The following is a description of a gene set: Human Gene Set: GOBP_POSITIVE_REGULATION_OF_CYTOSKELETON_ORGANIZATION Any process that activates or increases the frequency, rate or extent of the formation, arrangement of constituent parts, or disassembly of cytoskeletal structures. species: Homo sapiens, and this is the list of marker genes: MAPK15, CD47, NCK1, TRPV4, WNT4, KIRREL1, SEMA5A, ARL2, SDC4, WHAMM, DSTN, SERPINF2, CCDC15 (coiled-coil domain containing 15), PFN3, ARHGEF15 (Rho guanine nucleotide exchange factor 15), RHOC, STMN2, CDC42, BAIAP2, P2RX7, BMP10, ARHGEF10, DCTN1, CARMIL1, BAIAP2L2, MECP2, TPM1, PTK2B (protein tyrosine kinase 2 beta), PRKCE, NUP62, MTOR, AMOT, MTSS1, PPM1E, CTTN, DYNC1H1, SPAST (spastin), SKA1, PFN1, SMAD3, MET, EDN1, HCK, NUMA1, HSPA1B, RHOA, MYOC, SLAIN1, DLG1, CEP295, NCKAP1L, PDE4DIP, SORBS3, PLEK, GSN, RPS3, SLAIN2, SYNPO2L, OCLN, CDC42EP2, LPAR1 (NCBI Gene Id 1902), CCN2, ANKRD53, SWAP70, RAPGEF3, CFL1, SYNPO2, CKAP5, WASHC2C, PAK1, F2RL1, NCK2, KATNB1, PROX1, CDK5R1, CCR7, CCL11, WASF1 (WASP family member 1), WASF3, VASP, TACR1, FCHSD1, HSPA1A, GRB2 (NCBI Gene Id 80715), LIMCH1, CDC42EP4, LMOD1, NRP1, POC1B, CENPJ, CDC42EP3, AKAP9, CAV3, FER, CDKN1B, AURKB, FHOD1, FCHSD2, MAPRE1, CLIP1 (NCBI Gene Id 6249), LIMK1, SCIN, RAC1, CARMIL2, GPR65, GIT1, PYCARD (PYD and CARD domain containing), BRK1, VPS4B, APOA1, FLNA, CCL24, CDC42EP1, GPSM2, MYLK3, SNX9, ARPC2, NCKAP1, ROCK2, MIR1-1, CFL2, MLST8, CEP120, PSRC1, ALOX15, PPM1F, BRAF, ABI2, C15orf62, SFRP1, PDXP, VIL1, MAPT, LMOD2, ADD3, WASF2, ARF6, PFN2, CDC42EP5, CYFIP1, ARHGEF10L, SPAG5, TOGARAM1, BAIAP2L1, ARHGEF5, PFDN2, S100A10, ABL1, NAV3, CCDC88A, CCL26, SYNPO, TGFBR1, TAC1, WDR1, NES, PLK4, TESK1, PPP1R35, NPHS1, BAG4, BIN1, RGCC, CSF3, ITGB1BP1, NF2, EVL, FERMT2, CX3CL1, EPHA1, CRACD, CLASP1, PRKD1, PXN, ACTN2, DRG1, FES, RICTOR, CDK5RAP2, TRIM27, TGFB3, SASS6, KATNBL1, STIL, TENM1 (teneurin transmembrane protein 1), CCL21, MAP1B, PLXNA3, MAGEL2